The following is a description of a gene set: species: Homo sapiens Human Gene Set: MIR4281 Genes predicted to be targets of miRBase v22 microRNA hsa-miR-4281 in miRDB v6.0 with MirTarget v4 prediction scores > 80 (high confidence targets). from publication Chen Y, Wang X (PMID 31504780), and this is the list of marker genes: CDK5R2, ARB2A (NCBI Gene Id 83989), TRAIP, TGIF2, PTBP2, VAPB, TK2, CTTNBP2, TGFBR3L, RBBP4, BCL3, AZIN1, SMIM21, DUSP1, TRIQK, PPP4R3A, MYH9, PRRX1, TFAP2A (transcription factor AP-2 alpha), GRM5, DLST